The following is a description of a gene set: Mouse Gene Set: GOBP_NEGATIVE_REGULATION_OF_AXONOGENESIS Any process that stops, prevents, or reduces the frequency, rate or extent of axonogenesis. species: Mus musculus, and this is the list of marker genes: Plxna3, Thy1, Trim46, Cdh1, Slit1, Ptprs, Fgf13, Rnf6, Psen1, Ccr5, Ulk2, Sema5a, Ifrd1, Sema6c, Ttc3, Rgma (repulsive guidance molecule family member A), Sema6d, Dip2b, Ntn1, Spart, Sema3g, Sema4f, Actr3, Ryk, Mag, Tsc2, Cdk5, Slit2, Cdkl3, Pten, Tnr, Hdac6, Nrp1 (neuropilin 1), Mbp, Gdi1, Ptk2 (NCBI Gene Id 14083), D130043K22Rik, Sema3a, Bcl11a, Map2, Efnb3, Wnt3a, Rufy3, Epha7, Draxin, Mt3, Sema3f, Lrp4, Ulk1, Rtn4r, Wnt3, Dab1, Trak2, Arhgap4, Fstl4, Ephb2, Wnt5a, Rtn4, Syngap1